The following is a description of a gene set: Mouse Gene Set: GOBP_REGULATION_OF_T_CELL_CYTOKINE_PRODUCTION species: Mus musculus Any process that modulates the frequency, rate, or extent of T cell cytokine production., and this is the list of marker genes: Rsad2, Smad7, Il6, Ccl20, Malt1, Tbx21, Arg1, Vsir, Fzd5, Cd81, Dennd1b, Tnfsf4, Ccr2, Lilrb4b, Nlrp3, Cd55b, Foxp3, B2m, Slamf1, Hfe, Traf6, Gata3, Trpm4, Il18r1, Il1b, Ifnb1, Xcl1, Map3k7, Arid5a, Cd55, Traf2, Il4 (NCBI Gene Id 16189), Lilrb4a, Sash3, Tnfrsf1b, Il1r1, Il18, Prkcz